Given this list of marker genes ZBTB18, TPM2, CYB561D1, TP63, ACVR2A, NDP, ENO3, XK, NAT8L, PLEKHA6, SCAI, COL9A1, KCNK9, PCYT1B, PRMT3, BIRC2, ZBTB9, CRHBP, TENT5A, TNNI3K, NCKAP5, ZDHHC8, CKM, HAS2, RBM8A, JUN, DNAJA2, EYA1, MYH6 (NCBI Gene Id 4624), GPC4 (NCBI Gene Id 2239), SPTAN1, CDKL5, TENM3-AS1, GNAI2, FILIP1, TECR, SV2A, BNC2, KLHL40, AGBL4, SOX2, HOXA2, RHOBTB1, CNTN1, B4GALT1, TNNC1, CLIC1, CCDC85B, CTNNA3, HOXB8, SLCO2A1, SLC39A13, USP47, SLC24A2, TUBA4A, HJV, MTUS1, ANKMY2, SSPN, AZIN1, NR0B2, CTBP2, DLGAP4, PAK6, ARHGEF2, FAM110D (family with sequence similarity 110 member D), PPARGC1A, FGF16, MID1, SLC4A4, DLG2 (discs large MAGUK scaffold protein 2), ABCA6, RORB, SNCAIP, PPP1R10, VSTM2L, BEND4, JMJD1C, NOG, CREB5 (NCBI Gene Id 9586), GAL3ST3, BDNF, PABPC4, ASB16, DOCK8-AS1, CAPN1, STX5, ITGA7, CHRDL1 (chordin like 1), PRRX1, DCTN1, PURA, SSH3, JCHAIN, SDC1, SLC50A1, NFIB, DBNDD2 (dysbindin domain containing 2), SLC35A2, PYY (NCBI Gene Id 5697), CKMT2 (NCBI Gene Id 1160), ZFP36L1, ZNF362, CNTLN, ZCWPW1, ARHGEF15, MAS1, JAZF1 (NCBI Gene Id 94314), GRIN2B, UXS1, RTP1, B3GLCT, HS3ST5, FGF13, FGF9, FST, SLC3A1, PPP2R2B, HOXA10, DKK1, SEMA3A, EDN1, MYO9A, TBX4, HMGN2, LIN28A, H2BC5, CACNG3, TACR1, SALL3, NRP2, ACTA1, OLIG3, CASQ2, CHD2, RBBP6, HIVEP3, NEDD4, SMARCA1, MYL2, H1-4, MEPCE, CHMP1B, ZNF281, PDLIM1, RTBDN, PACS1, NEXN-AS1, ENSG00000204117, ARHGEF37, NFAT5, RIPOR1, EHD4, MYL6B, SALL1, ETV1, PRPF38B, FSBP, HOXB6, C2CD2L, PYY2, BACE2, COL13A1, CLASP1, TSPEAR, RTN1, XIRP1, WT1-AS, NR4A1, MBNL2, GABRA6, BHLHE22, CYP26B1, ASB18, RUNX2, CA7 (NCBI Gene Id 766), DIP2B, AFF3, TLCD5, LMCD1, NOX3, BZW2, CDC42EP3, PACSIN3, ZNF516-DT, P2RX5, HOXC6, MSTN, ZNF385B, WIF1, LUC7L3, HAPLN1, MRPS18B, TTN, ZNF436, FLT1, S1PR1 (NCBI Gene Id 51546), HMGB4, YPEL5 (NCBI Gene Id 51646), GTF2A1, SLITRK1, ATP5PD, USP2, UBXN10, TLE3, SOX5, USP13, GNAO1, MYL1, TUBA4B, BCL9L, HLX, JUND, PPP1R16B, HOXB5, KPNA3, NLK, NCAN, TBC1D16, ELMO3, PENK, GET4, BEST3, SLC26A9, PDZRN4, ZNF436-AS1, LUZP1, MACO1, SLC44A1 (NCBI Gene Id 63942), CACNB3, INPPL1, ARK2N, RFX3, ANKRD39, TGFB3, RGS3, ARL4C, STARD7, ELAVL2, GPR27, CPNE1, DYRK2, ASIC2, FBXW11, TSPAN14, ARPP21, PTCHD4, GSC, ATL2, MPC2, ESRRG, LYN, SMYD1, WDR81, HDAC9, GJB6, SOX15, HTR7, LINC03040, KRT222, PHKA2, CRTAP, GEN1, CDH10, LSMEM2, here is a description of the gene set: Human Gene Set: AMEF2_Q6 Genes having at least one occurrence of the motif CKGDYTAAAAATAACYMM in the regions spanning 4 kb centered on their transcription starting sites. This matches the transcription factor binding site V$AMEF2_Q6 (v7.4 TRANSFAC). studied in species Homo sapiens